The following is a description of a gene set: studied in species Homo sapiens Human Gene Set: GOBP_PROTEIN_K27_LINKED_UBIQUITINATION A protein ubiquitination process in which a polymer of ubiquitin, formed by linkages between lysine residues at position 27 of the ubiquitin monomers, is added to a protein., and this is the list of marker genes: MARCHF5, AMFR, UBE2T, RNF126, UBE2D4, RNF6, TRIM62, UBE2S, UBR4 (ubiquitin protein ligase E3 component n-recognin 4), RNF185, PRKN (NCBI Gene Id 8004), WSB1, TRIM21